The following is a description of a gene set: Estrogen metabolism Human Gene Set: WP_ESTROGEN_METABOLISM_WP697 studied in species Homo sapiens, and this is the list of marker genes: GSTA1, UGT1A6, CYP1A1, SULT1E1, COMT, CYP1A2, NQO1, CYP3A4, ARSL, UGT1A9, UGT1A3, ARSD, GSTM1, UGT2B7, STS, SULT1A1, UGT1A1, CYP1B1